Given this list of marker genes Pagr1a, Ncor2, Carm1, Trerf1, Rxrb, Scgb2a2, Brca1, Fkbp4, Atp1a1, Ddx17, Crh, Phb2, Axin2, Ncoa2, Calr, Ugt1a6b, Agtr1a, Usp26, Cry1, Cnot1, Kdm3a, Edn1, Npas4, Tmf1, Aifm1, Star, Ube2l3, Errfi1, Ccl2, Ugt1a6a, Akr1c18, Ncor1, Mgarp, Bmp4, Ace, Esrrb, Dnaja1, Cry2, Egfr, Ntrk2, Zfp764l1, Adcyap1, Ubr5, Smyd3, Foxh1 (NCBI Gene Id 14106), Nr3c1, Stc1, Srarp, Gper1, Ufl1, Eif4ebp1, Strn3 (NCBI Gene Id 94186), Sstr3, Mettl21c, Kdm4c, Gjb2, Lmo3, Anxa1, Foxo1, Jak2, Ugt1a1, Med1, Eif4e, Pou4f2, Ddx5, Gdnf, Foxp1, Gh, Ufsp2, Taf7, Padi2, Zfp36l1, Scnn1a, Sva, Wbp2, Klf9, Ppara, Bdnf, Calcoco1, Trp63, Ywhah, Bmi1, Vps18, Ar, Zmiz1, Esr2, Ppp5c, Vps54 (VPS54 GARP complex subunit), Ghrhr, Bmal1, Fech, Nodal, Acod1, Mapk1, Kdm5d, Sstr4, Park7, Rbfox2 (NCBI Gene Id 93686), Or51e2 (NCBI Gene Id 70818), mt-Nd3, Uri1 (NCBI Gene Id 97390), Crebrf (NCBI Gene Id 77128), Vps11, Nr0b1 (NCBI Gene Id 11614), Casp9, Zbtb7a, Sirt1, Sfrp1, Agtr2, Lbh, Tbx2, Abcb1a, Pias2, Zfp747, Skp2, Ube3a, Foxo3, Sstr5, Gstp1, Mir21a, Npc1, Esrrg, Daxx, Ncoa1, Pck1, Per1, Ddrgk1, Pck2, Heyl, Tfpi (NCBI Gene Id 99406), Cyp7b1, Rhoa, Trip4, Cnot3, Rwdd1, Lats1, Gsk3a, Nedd4, Isl1, Scnn1b, Esrra, Ep300, Safb2, Smarca4, Atp1a2, Igf1, Cst11, Sstr2, Atp5f1a, Kank2, Dab2, Fshr, Zfp747l1, Hdac1, Akap13, Pten, Zfp366, Arid1a, Tcf21, Fbxo32, Sgk1, Dnaaf4, Clock, Safb, Ifnb1, Nr3c2, Nkx3-1, Zfp36l2, Mstn, Aqp1, Prmt2, Fam107a, Sox10, Ddit4, Abhd2 (abhydrolase domain containing 2), Rxrg, Zfp36, Parp1, Shq1, Scnn1g, Uba5, Trim68, Rnf14, Hmga2, Agtr1b, Zfp764, Tgfb1, Trim63, Zdhhc7, Ncoa3, Rps6kb1, Rxra, Rest, Myod1, Pde3a, Pgr (progesterone receptor), Pak1, Cnot9, Cnot2, Mir155, Ppargc1b, Kmt2d, Ptges3, Rnf6, Esr1, Hmgcs2, Gsk3b, Cyp1b1, Src, Ass1, Serpinf1, Ufm1, Hnrnpu, Foxa1, Il17a, Phb1, Etnppl, here is a description of the gene set: Mouse Gene Set: GOBP_CELLULAR_RESPONSE_TO_STEROID_HORMONE_STIMULUS Any process that results in a change in state or activity of a cell (in terms of movement, secretion, enzyme production, gene expression, etc.) as a result of a steroid hormone stimulus. studied in species Mus musculus